Given this list of marker genes DHFR, CDH1, BCKDHA, IRS2, DHCR7, CENPA, DDX39A, CCNB2, KIF11, CALCB (NCBI Gene Id 797), ERBB3, USH1C, DDC (dopa decarboxylase), CTH, KIF23, TOP2A, NOTCH3, UBE2S, EGFR, here is a description of the gene set: Human Gene Set: JEON_SMAD6_TARGETS_DN studied in species Homo sapiens from publication Jeon HS, Dracheva T, Yang SH, Meerzaman D, Fukuoka J, Shakoori A, Shilo K, Travis WD, Jen J (PMID 19047146) Genes down-regulated in H1299 cells (lung cancer) upon knockdown of SMAD6 by RNAi. The malignant transformation in several types of cancer, including lung cancer, results in a loss of growth inhibition by transforming growth factor-beta (TGF-beta). Here, we show that SMAD6 expression is associated with a reduced survival in lung cancer patients. Short hairpin RNA (shRNA)-mediated knockdown of SMAD6 in lung cancer cell lines resulted in reduced cell viability and increased apoptosis as well as inhibition of cell cycle progression. However, these results were not seen in Beas2B, a normal bronchial epithelial cell line. To better understand the mechanism underlying the association of SMAD6 with poor patient survival, we used a lentivirus construct carrying shRNA for SMAD6 to knock down expression of the targeted gene. Through gene expression analysis, we observed that knockdown of SMAD6 led to the activation of TGF-beta signaling through up-regulation of plasminogen activator inhibitor-1 and phosphorylation of SMAD2/3. Furthermore, SMAD6 knockdown activated the c-Jun NH2-terminal kinase pathway and reduced phosphorylation of Rb-1, resulting in increased G0-G1 cell arrest and apoptosis in the lung cancer cell line H1299. These results jointly suggest that SMAD6 plays a critical role in supporting lung cancer cell growth and survival. Targeted inactivation of SMAD6 may provide a novel therapeutic strategy for lung cancers expressing this gene.